The following is a description of a gene set: The initial step in phagocytosis involving adhesion to bacteria, immune complexes and other particulate matter, or an apoptotic cell and based on recognition of factors such as bacterial cell wall components, opsonins like complement and antibody or protein receptors and lipids like phosphatidyl serine, and leading to intracellular signaling in the phagocytosing cell. Human Gene Set: GOBP_PHAGOCYTOSIS_RECOGNITION studied in species Homo sapiens, and this is the list of marker genes: PLA2G5, COLEC11, TULP1, SFTPA1, MYO18A, C4B, C4BPA, CLEC7A, ADGRB1 (adhesion G protein-coupled receptor B1), PEAR1, CFP, LBP, MEGF10, PTX3, CD36, TREM2, FCN3, SCARB1, C4BPB, FCN2, FCGR1A, SPON2, JMJD6, COLEC12, FCN1, CRP, COLEC10, MBL2, TUB